The following is a description of a gene set: Episodes of fever for which no infectious cause can be identified. Human Gene Set: HP_UNEXPLAINED_FEVERS species: Homo sapiens Unexplained fevers, and this is the list of marker genes: ADAR, RNASEH2A, RNU7-1, GALC, AQP2, LAMA3, RNASEH2B, NTRK1, TMEM165, TREX1, RNASEH2C, SAMHD1, PSAP, NKX2-1, LAMC2, AVPR2, IFIH1, LAMB3, CRLS1, LSM11